Given this list of marker genes DUSP11, NR1I2, ABCE1, NCL, UCHL3, BUB1B, KIF11, KNTC1, SSBP2, PSMC6, CAPZA1, MTA1, DLD, LMNB2, CHEK1, H4C3, TPP2, CDC23, SPAG5, PSMA5, YAF2, RIF1, SMPD4, COX6C (NCBI Gene Id 1345), SMNDC1, EIF3M, ATR, RHOH, FADS1, SNRPE, YY1, YBX1P5, NSA2, WRN, NUTF2, CDC123, CUL4A, POLR3G, TNFRSF17, C1D, SPC25, MCM3, SH2D1A, CCNC, KHDRBS1, SNRPG, GCH1, GIP, AIMP1, SMC4, RAD51AP1, HNRNPAB, FTSJ1, CEBPG, RGS13, CDC7 (NCBI Gene Id 8317), TCEA1, GPR18, CDC20, MIEF1, RRP1B, SQLE, YBX1, PRPF4, ZNF35, SNRPD2, DDX10, TTF1, SNRPF, USP13, RNASEH1, RFC5, RPL6, NECTIN1, GINS1 (NCBI Gene Id 9837), POT1, EXOG, EWSR1, LAMC2, IARS2, TAF2, HS2ST1, PRDX3 (NCBI Gene Id 29017), PSMA4, SMC2, MNAT1, BRCA2, SRP19, MIF, NUP205, DDX18, DUSP7, SYK, BCAT1 (branched chain amino acid transaminase 1), SNRPB2, PSMA2 (proteasome 20S subunit alpha 2), UBAP2L, AFF2, PRMT1 (NCBI Gene Id 3276), KIF14 (kinesin family member 14), MAPKAPK5, GMPS, DHX9, CCNF, PWP1, KATNA1, SMN1, CHUK, MPHOSPH10, PCLAF, GTF2E1, PAXIP1, RMND5A, LARP7, PTMA, GNL2, PUM3, FRG1, RBBP4, MYO1A, UTP18, LSM6 (NCBI Gene Id 730962), UCK2, BOP1, COX11, DCK, DDX52, DPH2, EEF1B2, RANBP1, FDFT1, HDAC1, EIF4H, NAP1L4, CSE1L, TAF11, XRCC6, PAX2, NUDT1, HSPH1, UBE2C, NCK1, PART1, LIG1, CEBPZ, POM121, CDC6, EXOSC8, GTF2E2, TUBGCP3, ACAT2 (NCBI Gene Id 39, acetyl-CoA acetyltransferase 2), ITGB3BP, ILF2, BET1, PELP1, PSMA6, CDT1, CD47, DIMT1, RPIA, ZNHIT3, HNRNPA2B1, CSNK2A1, POLR2J, ZNF195, MYBL2, PRPF19, PGK1, KRT20, PSMC2, MELK, SRSF10, CNOT9 (CCR4-NOT transcription complex subunit 9), CKS2, EIF2S1, HSPA9, NDC80 (NDC80 kinetochore complex component), TACR3, TFDP2, NUP62, NF1, POLR3C, TIMELESS, PNO1, IL17A, GTPBP1, CD1E, TRIP13, TFRC, SMG7, BUB1, CDK4, CEP57, MTF2, CCNB1, GTF2A2, TFDP1, NRL, CENPA, PFAS, BLM, KIFC1, EEF1E1, CENPI, IFT25, NME1, SLC7A5, RPA3, OXA1L, HAUS3, CTCF, NAA10, SNRPA1, PIAS2, NUP153, MTAP, POU2AF1, AGL, SYNCRIP (synaptotagmin binding cytoplasmic RNA interacting protein), GTF3A, CCT3, TMPO, NCBP1, KPNA2, DGUOK, CHAF1A, MED24, PARG, CD19, SLC16A1, MSH2, PRR3, EXO1, TRIM24 (NCBI Gene Id 8805), MED21, RAD9A, H2AZ1, PLK4, THAP12, RNASEH2A, ZBTB33, NOP14, MPHOSPH9, RAD1, RRS1, MCM4, NGDN, CCNE2, TP53TG1, DESI2, LSM7, SNRPC, LARP4B, SMC1A, EIF2S2, TXNL4A, RPL23, DNAJC9, SMARCD1, NCAPD2, CCNA2, CNIH1, SIKE1, PSMD3, PPID, HSPE1, PPIG, XPNPEP1, IDI1, CDV3, ATP13A3, NSL1, PLK1, UBE2S, RAD51C, CDK1, YWHAB, TOP2A, RNFT2, TOP1, RAD54L, POP5, TMEM131L, DHFR, HNRNPL, TTI1, IFT20, FANCI, MRPL3, TRA2B, HMGN3, PGAP2, TROAP, PPIA, MTDH, MED20, EIF5B, TOE1, SEM1, AP3S1, KHSRP (NCBI Gene Id 8570), TTK, PARP1, AURKB, IRF4, POLA1, NBR2, RCN2, PSMA3, VBP1, PPP2R1B, DNAJC2, NUP88, PNN, NDUFV2 (NCBI Gene Id 4729), HPRT1, FEN1, PTTG1, NAP1L1, IRAK1, ILF3, SLC25A5, TYMS, NONO, RPL4, STK24, SNRNP200, PIK3CG, WTAP, WDR77 (NCBI Gene Id 79084), TAF5L, ODC1, RBMX, MRPL19 (mitochondrial ribosomal protein L19), STMN1, NUP160, BAZ1B, ENSG00000240291, NOP56, ZBTB24, WDHD1, HNRNPF, SLC7A1 (NCBI Gene Id 6541), NPM1, BZW1, KLHL23, GTF2B, DMAC2L, BARD1, TFAM (NCBI Gene Id 8033), GTSE1, MAD2L1, RPS7, CD1C, SNRPD3 (NCBI Gene Id 6634), CTR9, PDCD10, SET, NSD2, CBFB, DBI, POLR2H (NCBI Gene Id 5437), PSIP1 (PC4 and SRSF1 interacting protein 1), GPN1, RPS27A (ribosomal protein S27a), MPHOSPH6, ANAPC5, DEK, RB1, ASF1A, TAF9, RNF126, MTHFD2, ANAPC10, RAD21, TBCA, HNRNPH1, WDR43, INSIG1, URB2, CTBP1, PRKDC, HNRNPC, H3C11, RFC4, ATM, TARDBP, HMGB2, LSM5, GALNT1, E2F5, ATP11B (NCBI Gene Id 348830), PA2G4, POP4, NACA, TPX2, NCBP2, UBE2E1, HNRNPR (NCBI Gene Id 10236), CNOT1, UBE2G1, PPP2R5C (protein phosphatase 2 regulatory subunit B'gamma), LYPLA1, SSB, CHERP, DNMT1, MED6, SMC3, IARS1, MKI67, LPXN, DNA2, NPM3, U2AF1, PAFAH1B3, TRIM31, PSMB4, THOP1, PLAGL2, MAGOH, BAZ1A, TOMM40 (NCBI Gene Id 10452), RCC1, DLEU1, EPB41, UBE2N, CHRNA5, CCT2, ACTL6A, CPT1A, RECK, STAT5A, NOLC1, BOLA2, AHSA1, SRSF3, ERH, BTF3P11, FGF8, RBCK1, PABPC1, CENPF, NOP2, KIF2C, GCFC2 (NCBI Gene Id 6936), RBBP8, FOXM1, ELOC, ZNF22, TCF3, CCT8, EIF4E, POLE2, ATP5PF, IL4, POLE3, PSMD9, CTPS1, XRCC5, BTF3, UBA2, RPS6, PRKRA, GOLIM4, KDM4A, HSP90AA1, ATP5MJ, CDKN2C, CBX3, FABP5, PCNA, ZNF337, GCSH (NCBI Gene Id 2653), BUB3, POLE, WNT11, PPP2R5E, OIP5, SNX4, HIRA, BRCA1, SRSF9, GNPAT, SEC61G, NFYB, IDH3B, RBBP6, IMMT, RPL27, NUFIP1, SSBP1, TIMM8A (translocase of inner mitochondrial membrane 8A), MSH5, CCT4, ETFA (NCBI Gene Id 2108), CD1B, TRIAP1, EIF4A3, UTP20, PPP1R8, PLCG2, PRPSAP2, SUMO1, HDGF, EIF5AL1, LCT, ADSL, UBL4A, SRSF1, SNRPB, PSMA1, SART3, NHP2, TDG, LMNB1, C1QBP, SRSF11, COPS3, MTERF1, MSH6, TUBA1B, RBM34 (NCBI Gene Id 23029), RFX5, MCM2, NAT1, MCM7, COX7B, NFATC2IP, NASP, ATIC, ATXN10, HNRNPA3, PCGF1, SMARCA5, FAM216A, POLG, POLR2G, RUVBL1, RRP7A, DDX39B (DExD-box helicase 39B), LDHB, DLGAP5, TATDN2, FBL, CDC45, KIF20B, HMGCR, SELENOF, SUZ12 (NCBI Gene Id 23512), NDUFB3, DNTTIP2, PRPS1, TM9SF4, BLMH, LSM1, CTAG2, IPO5, HMGN1, TOPBP1, DARS1, RBM14, DCP2, ERCC3, USP1, ZNF131 (zinc finger protein 131), RPA1, EIF3H, PCMT1, TTC39A, DUT, CENPE, SSRP1, SNRPA, TIMM17A, ARHGAP19, PSME2, DDX46, MTCP1, UBE2I, SHMT2, CNBP, UNG, MCM5 (NCBI Gene Id 4174), MYBPH, AURKA, CD2AP, TAF5, IDO1, CPSF4, PFDN4, HAT1, RRM1, ZNF330, PDS5A, GNA13, ZWINT, ADNP, HMGN2, KARS1, HMGB1P8, KRAS, NOP16, ATP5PO, NAE1, WEE1, EZH2, MAT2A, MOB1A, CYCS, PFDN6, OGG1, VRK1, PPP1CC, MTX2, KHDRBS2, RECQL, YWHAE, ELAC2, TCF20, MRPL58, ACLY, HMMR, H2AZ2, DBF4, UBE2D3, G3BP1, DNAJC24, HSPA8, SMARCC1, LSM3, CASP2, SMARCB1 (NCBI Gene Id 6598), HK2, NBN, RFC3, LSM4, HMGN4, ORC5, SMARCA4, PSMC3IP, SRP9, LCK (NCBI Gene Id 95387), FUBP1, CPSF6, MYC, PARP2, HDAC2, ADA, PRDX1, DLST, ABCB7, PMPCA, ATP5MF, SAR1A, ATG12, RNF2, TSR1, KRT76, DCAF7, FBLN1, TMEM106C, GEMIN2, TBP, RIMS1, ACYP1, GSR, ARHGAP11A, SNRNP40, MRE11, UTP3, TFAP4, STIL, DDX39A, LARP4, CCNB2, FAM76A, AATF, TMEM243, DLAT, XPO1, ANXA13, CHEK2, RNASEH2B, THAP9-AS1, TBC1D31, PRMT3, DHX15, CNOT3, GNB3, CAD, HSPD1, DPM1, OXSR1, METAP2 (methionyl aminopeptidase 2), TMX1, CLPX, NMT1, ISG20L2, GLMN, HSPA4, EED, NUP210, NEMP1, HNRNPM, GSPT1, DTYMK, ZNF250, CCT5, LBR, SRSF2, BCL7A, WASHC5, POLR2B, SREK1IP1, MAK16 (MAK16 homolog), TAF4, SLC1A4, TCP1, RRM2, ADNP2, SRP72, CNTRL, CLP1, RECQL4, SLC7A6, CENPC, STARD7, ANP32E, BIK, ZC3H15, HMGB3, ESPL1, CKS1B, MCM6, CD79B, DDX21, TGDS (NCBI Gene Id 23483), FDPS, SP100, BPY2, KYAT3, MFAP1, TCL1A, TTF2, TMEM123, PTPN2, SEPHS1, PTTG2 (pituitary tumor-transforming 2), RAN, TCERG1, SLBP, PRRC2C, NOX1, SFPQ, RB1CC1, ZNF43 (NCBI Gene Id 7594), GTF2H4, DKC1, PAICS, METAP1, ABCC10 (ATP binding cassette subfamily C member 10), LDHA, here is a description of the gene set: Human Gene Set: PUJANA_CHEK2_PCC_NETWORK from publication Pujana MA, Han JD, Starita LM, Stevens KN, Tewari M, Ahn JS, Rennert G, Moreno V, Kirchhoff T, Gold B, Assmann V, Elshamy WM, Rual JF, Levine D, Rozek LS, Gelman RS, Gunsalus KC, Greenberg RA, Sobhian B, Bertin N, Venkatesan K, Ayivi-Guedehoussou N, Solé X, Hernández P, Lázaro C, Nathanson KL, Weber BL, Cusick ME, Hill DE, Offit K, Livingston DM, Gruber SB, Parvin JD, Vidal M (PMID 17922014) studied in species Homo sapiens Many cancer-associated genes remain to be identified to clarify the underlying molecular mechanisms of cancer susceptibility and progression. Better understanding is also required of how mutations in cancer genes affect their products in the context of complex cellular networks. Here we have used a network modeling strategy to identify genes potentially associated with higher risk of breast cancer. Starting with four known genes encoding tumor suppressors of breast cancer, we combined gene expression profiling with functional genomic and proteomic (or 'omic') data from various species to generate a network containing genes linked by 866 potential functional associations. This network shows higher connectivity than expected by chance, suggesting that its components function in biologically related pathways. One of the components of the network is HMMR, encoding a centrosome subunit, for which we demonstrate previously unknown functional associations with the breast cancer-associated gene BRCA1. Two case-control studies of incident breast cancer indicate that the HMMR locus is associated with higher risk of breast cancer in humans. Our network modeling strategy should be useful for the discovery of additional cancer-associated genes. Genes constituting the CHEK2-PCC network of transcripts whose expression positively correlates (Pearson correlation coefficient, PCC >= 0.4) with that of CHEK2.